Given this list of marker genes Tpbg, Mup20, Adcy3, Gucy2d, Drd4, Grin1 (NCBI Gene Id 14810), here is a description of the gene set: Mouse Gene Set: GOBP_OLFACTORY_LEARNING Any process in an organism in which a relatively long-lasting adaptive behavioral change occurs in response to (repeated) exposure to an olfactory cue. species: Mus musculus